The following is a description of a gene set: Any process involved in forming the mature 3' end of an RNA molecule transcribed from a mitochondrial genome; occurs in the mitochondrion. Human Gene Set: GOBP_MITOCHONDRIAL_RNA_3_END_PROCESSING studied in species Homo sapiens, and this is the list of marker genes: SUPV3L1, HSD17B10, ANGEL2, TRMT10C, PNPT1, MTPAP, TRNT1, ELAC2